Given this list of marker genes H2BC11, CDK1 (cyclin dependent kinase 1), MTBP, SMC5, H4C16, SPDL1, H4C15, HASPIN, H4C3, H4C9, TTK, H4C8, JARID2, TRAPPC12, AURKB, H4C12, BUB3, IK, H2AC8, KNTC1, CTCF, BUB1B, CENPA, H2AC4, H4C2, H4C5, H4C14, MIS18A, KNL1, RCC2, CHAMP1, H4C11, H4C1, ZWILCH, H4C4, RB1, H4C6, CENPQ, ZW10, BOD1, H4C13, here is a description of the gene set: Human Gene Set: GOBP_PROTEIN_LOCALIZATION_TO_CHROMOSOME_CENTROMERIC_REGION Any process in which a protein is transported to, or maintained at, the centromeric region of a chromosome. studied in species Homo sapiens